The following is a description of a gene set: The regulated release of pancreatic juice by the exocrine pancreas into the upper part of the intestine. Pancreatic juice is slightly alkaline and contains numerous enzymes and inactive enzyme precursors including alpha-amylase, chymotrypsinogen, lipase, procarboxypeptidase, proelastase, prophospholipase A2, ribonuclease, and trypsinogen. Its high concentration of bicarbonate ions helps to neutralize the acid from the stomach. studied in species Mus musculus Mouse Gene Set: GOBP_PANCREATIC_JUICE_SECRETION, and this is the list of marker genes: Vamp8, Nr1h2, Aqp5, Cel, Sct, Wnk3, Stk39, Madd, Copa, Mmp13, Aqp1, Wnk4, Wnk1, Npr3, Nr1h3